The following is a description of a gene set: Human Gene Set: PID_GMCSF_PATHWAY GMCSF-mediated signaling events species: Homo sapiens from publication Schaefer CF, Anthony K, Krupa S, Buchoff J, Day M, Hannay T, Buetow KH (PMID 18832364), and this is the list of marker genes: SOS1, STAT1, PTPN11, MAPK1, RAF1 (NCBI Gene Id 5894), MAP2K2, CSF2, STAT5A, PIK3R1, PIK3CA, PIM1, IKBKB, SHC1, CSF2RB, KRAS, MAP2K1, YWHAZ, PRKACB, STAT5B (NCBI Gene Id 6777), HRAS (HRas proto-oncogene, GTPase), GRB2, NRAS, PRKACA, STAT3, LYN, GAB2, SYK, IRF8, CSF2RA, CCL2, CISH, FOS, OSM, PRKACG, JAK2, MAPK3